The following is a description of a gene set: part of: SLC transporter disorders The nuclear pore complex (NPC) trafficks cargo across the nuclear membrane. Nucleoprotein TPR functions as a scaffolding element in the nuclear phase of the NPC essential for normal nucleocytoplasmic transport of proteins and mRNAs. The complex glucokinase (GCK1) and glucokinase regulatory protein (GKRP) can be translocated to the nucleus via the NPC. Defects in TPR may confer susceptibility towards thyroid papillary carcinona (TPC; MIM:18850), a common tumor of the thyroid that typically arises as an irregular, solid or cystic mass from otherwise normal thyroid tissue. species: Homo sapiens Reactome Pathway: Defective TPR may confer susceptibility towards thyroid papillary carcinoma (TPC), and this is the list of marker genes: SEC13, GCKR, POM121, NUP50, NUP43, NUP62, RANBP2, NUP188, NUP133, NUP153 (nucleoporin 153), GCK, NUP35, POM121C, NUP58, NUP214, NDC1, NUP210, NUP42, NUP37, NUP160, NUP54, NUP98, NUP85, NUP93, RAE1, NUP88, NUP155, NUP107, TPR, NUP205, AAAS, SEH1L